Given this list of marker genes C16orf87, ORC6, RAB43P1 (NCBI Gene Id 440375), GPT2, ANKRD26P1, VPS35, DNAJA2-DT, CKBP1, RNU6-845P, DNAJA2, MYLK3 (myosin light chain kinase 3), SHCBP1, here is a description of the gene set: Human Gene Set: chr16q11 species: Homo sapiens